Given this list of marker genes ATG13, ULK1 (NCBI Gene Id 8408), TP53, GABARAP, RB1CC1, TRAF2, RB1, WDR45B, GABARAPL1, GABARAPL2, MAP3K5, PTK2B (NCBI Gene Id 5748), ATG101, TNF, ATG16L1, PTK2, here is a description of the gene set: species: Homo sapiens Human Gene Set: WP_8Q1123_RB1CC1_COPY_NUMBER_VARIATION 8q11.23 (RB1CC1) copy number variation